The following is a description of a gene set: Mouse Gene Set: GOBP_REGULATION_OF_CELL_ADHESION_MOLECULE_PRODUCTION Any process that modulates the rate, frequency or extent of cell adhesion molecule production. Cell adhesion molecule production is the appearance of a cell adhesion molecule as a result of its biosynthesis or a decrease in its catabolism. species: Mus musculus, and this is the list of marker genes: Apoa1, Myocd, Ifnb1, Fut7, Crebbp, Cav1, Notch4, Aqp4, Notch1